The following is a description of a gene set: studied in species Homo sapiens The chemical reactions and pathways by which one-carbon (C1) units are transferred between tetrahydrofolate molecules, to synthesize other tetrahydrofolate molecules. Human Gene Set: GOBP_TETRAHYDROFOLATE_INTERCONVERSION, and this is the list of marker genes: MTHFD1, MTHFS, MTHFD2, SHMT1, TYMS, SHMT2, MTHFD2L, MTHFR, MTHFD1L (NCBI Gene Id 80244), ALDH1L1